Given this list of marker genes RELN, C1QL2, LRFN4, LRFN1, LATS1, NPTX1, C1QL3, PTPRS, ABI3, ZDHHC12, LRRTM2, PTPRD, PTK2B, PTEN, NTRK3, NLGN2, NRXN2, FGFR1, CBLN1, SLITRK3, CASKIN1, LRRC4B (NCBI Gene Id 94030), SHANK3, GRID2, NRXN1, IL1RAP, CSMD2, CRIPT (CXXC repeat containing interactor of PDZ3 domain), PRICKLE1 (prickle planar cell polarity protein 1), here is a description of the gene set: studied in species Homo sapiens Human Gene Set: GOBP_POSTSYNAPTIC_DENSITY_ASSEMBLY The aggregation, arrangement and bonding together of a set of components to form a postsynaptic density, a region that lies adjacent to the cytoplasmic face of the postsynaptic membrane at excitatory synapse.